The following is a description of a gene set: electronically inferred by orthology from the curated human pathway part of: Respiratory electron transport species: Mus musculus This event has been computationally inferred from an event that has been demonstrated in another species.<p>The inference is based on the homology mapping from PANTHER. Briefly, reactions for which all involved PhysicalEntities (in input, output and catalyst) have a mapped orthologue/paralogue (for complexes at least 75% of components must have a mapping) are inferred to the other species. Reactome Pathway: Complex III assembly, and this is the list of marker genes: Uqcr10, mt-Cytb, Cyc1, Fxn (NCBI Gene Id 14297), Iscu, Lyrm4, Uqcrc2, Uqcrfs1, Uqcr11